The following is a description of a gene set: Mouse Gene Set: GOCC_ESCRT_I_COMPLEX studied in species Mus musculus An endosomal sorting complex required for transport. It consists of the class E vacuolar protein sorting (Vps) proteins and interacts with ubiquitinated cargoes., and this is the list of marker genes: Mvb12a, Vps28, Mvb12b, Vps37d, Vps37b, Tsg101, Vps37a, Ubap1l, Uevld, Diaph3, Vps37c, Ubap1